The following is a description of a gene set: studied in species Homo sapiens Human Gene Set: HP_UNDETECTABLE_LIGHT_AND_DARK_ADAPTED_ELECTRORETINOGRAM Undetectable light- and dark-adapted electroretinogram Absence of the combined rod-and-cone response on electroretinogram., and this is the list of marker genes: MT-ATP6, RPGRIP1, CLRN1, IMPDH1, RP9, PCYT1A, AIPL1, NUP54, ADAR, NUP62, NR2E3, CERKL, RPE65, RP1